Given this list of marker genes SNAP25, IFNL1, PTPRZ1, CSF3, CSF3R, IL34, CASP3, IL32, JAK1, SDC1, TXLNA, IFNLR1, TYK2, STX4, STX3, PRTN3, IL10RB, VAMP2, CD4, CSF1, STX1A (syntaxin 1A), CSF1R, IL16, STXBP2, here is a description of the gene set: part of: Signaling by Interleukins species: Homo sapiens Reactome Pathway: Other interleukin signaling Interleukins are low molecular weight proteins that bind to cell surface receptors and act in an autocrine and/or paracrine fashion. They were first identified as factors produced by leukocytes but are now known to be produced by many other cells throughout the body. They have pleiotropic effects on cells which bind them, impacting processes such as tissue growth and repair, hematopoietic homeostasis, and multiple levels of the host defense against pathogens where they are an essential part of the immune system.